Given this list of marker genes LPAR4, THEMIS (NCBI Gene Id 387357), IKZF2, MTX3, SLITRK4, PKD2L2, VGLL3, SKIL (SKI like proto-oncogene), ALG10B, BEX1, ELMOD2, KIF14, VPS26C, ANOS1, ZDHHC21, PLAGL1, CENPW, PCBP1, CNTN3, GALNT4, EPHA7, CDK15, LTBP3, HOXC4, SMOC2, POC1B-GALNT4, here is a description of the gene set: from publication Chen Y, Wang X (PMID 31504780) Genes predicted to be targets of miRBase v22 microRNA hsa-miR-10a-3p in miRDB v6.0 with MirTarget v4 prediction scores > 80 (high confidence targets). Human Gene Set: MIR10A_3P studied in species Homo sapiens